Given this list of marker genes FPR1, CXCL12, CCL18, C5, PPBP, CCL17, CXCL10, CCL14 (C-C motif chemokine ligand 14), DEFB1, CCL8, IL16, CCL13, CCL2, XCL1, PF4, CCL11, CX3CL1, CCR1, CXCL8, CXCL6, CCL4, CXCL1, C3AR1 (complement C3a receptor 1), CCL15, CXCR4, CXCL9 (NCBI Gene Id 4283), CCL19, PLAUR, CXCL5, CXCL14, CXCL2, CXCL11, CCL3, FPR2, CCL20, CCL23, CCR5, CCL21, PLAU, CXCR2, CCL7, CCL25, C5AR1, CXCL13 (NCBI Gene Id 115545), IL1A, here is a description of the gene set: studied in species Homo sapiens Human Gene Set: MODULE_263 Chemotaxis (chemokines).